Given this list of marker genes SLC34A1, here is a description of the gene set: Reactome Pathway: Defective SLC34A1 causes hypophosphatemic nephrolithiasis/osteoporosis 1 (NPHLOP1) part of: SLC transporter disorders SLC34A1 and 2 encode Na+/Pi cotransporters, which cotransport divalent phosphate (PO4(2-), Pi) with 3 Na+ ions. SLC34A1 is an important Pi transporter mainly expressed in renal proximal tubules where it plays a major role in Pi homeostasis. Defects in SLC34A1 are the cause of hypophosphatemic nephrolithiasis/osteoporosis type 1 (NPHLOP1; MIM:612286), disease characterised by decreased renal phosphate absorption, hypophosphatemia, hyperphosphaturia, hypercalciuria, nephrolithiasis and implicated in the formation of renal calcium stones and/or bone demineralisation. species: Homo sapiens